The following is a description of a gene set: species: Homo sapiens Any process that results in a change in state or activity of a cell or an organism (in terms of movement, secretion, enzyme production, gene expression, etc.) as a result of a macrophage colony-stimulating factor stimulus. Human Gene Set: GOBP_RESPONSE_TO_MACROPHAGE_COLONY_STIMULATING_FACTOR, and this is the list of marker genes: TREM2 (triggering receptor expressed on myeloid cells 2), ALPL, MST1R, TNF, FER, PTPN2, PDE2A, PDE1B, TLR4, DOK1, BGLAP, TLR2, SPP1, STAP1, CSF1, DCSTAMP, CSF1R